The following is a description of a gene set: Mouse Gene Set: GOBP_SYNAPTONEMAL_COMPLEX_ORGANIZATION species: Mus musculus A process that is carried out at the cellular level which results in the assembly, arrangement of constituent parts, or disassembly of a synaptonemal complex. A synaptonemal complex is a proteinaceous scaffold formed between homologous chromosomes during meiosis., and this is the list of marker genes: Mcmdc2, Syce2, Tex12, Hspa2, Plk1, Spo11, Rad21l, Ube2b, Ehmt2, Meioc, 1700028K03Rik, Ago4 (NCBI Gene Id 76850), Syde1, Terb2, Shoc1, Cpeb1, Tex11, Sycp1, Sycp3, 4930447C04Rik, Mlh3 (NCBI Gene Id 30788), Bag6, Rec8, Hormad1, Syce3, Tex15, Trip13, Syce1, Syce1l